Given this list of marker genes UGP2, PYGL, GYS1, HKDC1, HK1, SLC2A3, HK2, G6PD, HK3, SLC2A8, GCK, here is a description of the gene set: Human Gene Set: GOMF_D_GLUCOSE_BINDING Binding to D-enantiomers of glucose. studied in species Homo sapiens